Given this list of marker genes CMPK2, AK8, AK4, AK9, CMPK1, AK7, here is a description of the gene set: Catalysis of the reaction: ATP + (d)CMP = ADP + (d)CDP. species: Homo sapiens Human Gene Set: GOMF_D_CMP_KINASE_ACTIVITY